The following is a description of a gene set: studied in species Homo sapiens Human Gene Set: GOBP_CALCIUM_ION_REGULATED_EXOCYTOSIS_OF_NEUROTRANSMITTER The release of a neurotransmitter into the synaptic cleft by exocytosis of synaptic vesicles, where the release step is dependent on a rise in cytosolic calcium ion levels., and this is the list of marker genes: PPP3CA, ATP2A2, RIMS2, RAB3A, SNAP25, RAB3GAP1, CACNA1B, STXBP1, DOC2B, STX1B, CDK5, STXBP3 (syntaxin binding protein 3), SYT1 (NCBI Gene Id 6857), SYT7, STXBP2